Given this list of marker genes ZDHHC19, HSPB8, HTT, KAT5, CSNK2A1, BAG3 (BAG cochaperone 3), here is a description of the gene set: Any process that activates or increases the frequency, rate or extent of aggrephagy. studied in species Homo sapiens Human Gene Set: GOBP_POSITIVE_REGULATION_OF_AGGREPHAGY